Given this list of marker genes CACNG8, PRPF31, VSTM1, NDUFA3, TFPT, CACNG6, OSCAR, here is a description of the gene set: Genes within amplicon 19q13.4 identified in a copy number alterations study of 191 breast tumor samples. Human Gene Set: NIKOLSKY_BREAST_CANCER_19Q13.4_AMPLICON studied in species Homo sapiens from publication Nikolsky Y, Sviridov E, Yao J, Dosymbekov D, Ustyansky V, Kaznacheev V, Dezso Z, Mulvey L, Macconaill LE, Winckler W, Serebryiskaya T, Nikolskaya T, Polyak K (PMID 19010930) A single cancer cell contains large numbers of genetic alterations that in combination create the malignant phenotype. However, whether amplified and mutated genes form functional and physical interaction networks that could explain the selection for cells with combined alterations is unknown. To investigate this issue, we characterized copy number alterations in 191 breast tumors using dense single nucleotide polymorphism arrays and identified genes with copy number gain organized into 30 amplicons. Amplicons were distributed unequally throughout the genome. Each amplicon had distinct enrichment pattern in pathways, networks, and molecular functions, but genes within individual amplicons did not form coherent functional units. Genes in amplicons included all major tumorigenic pathways and were highly enriched in breast cancer-causative genes. In contrast, genes with somatic mutations in breast cancer were distributed randomly over the genome, did not represent a functionally cohesive gene set, and were relatively less enriched in breast cancer marker genes. Mutated and gained genes did not show statistically significant overlap but were highly synergistic in populating key tumorigenic pathways including transforming growth factor beta, WNT, fibroblast growth factor, and PIP3 signaling. In general, mutated genes were more frequently upstream of gained genes in transcription regulation signaling than vice versa, suggesting that mutated genes are mainly regulators, whereas gained genes are mostly regulated. ESR1 was the major transcription factor regulating amplified but not mutated genes. Our results support the hypothesis that multiple genetic events, including copy number gains and somatic mutations, are necessary for establishing the malignant cell phenotype.